Given this list of marker genes ORC5, ORC6, ORC4, ORC1, ORC2 (NCBI Gene Id 4999), ORC3, LRWD1, MCM2, here is a description of the gene set: Human Gene Set: GOCC_ORIGIN_RECOGNITION_COMPLEX A multisubunit complex that is located at the replication origins of a chromosome. studied in species Homo sapiens